Given this list of marker genes Cd46, C4bp, Vsig4, C3, Susd4, Il1b, Cr2, Cfhr4, Cd59b, Cd5l, Serping1, Cr1l, Trem2, Cd59a, Phb1, Mbl2, Masp1 (NCBI Gene Id 17174), Cd55 (NCBI Gene Id 13136), Cfh, Zp3r (NCBI Gene Id 98633), C1qbp, A2m, Cd55b, here is a description of the gene set: Any process that modulates the frequency, rate or extent of complement activation. Mouse Gene Set: GOBP_REGULATION_OF_COMPLEMENT_ACTIVATION species: Mus musculus